Given this list of marker genes SMARCA2, OGT, ARID4B, REST, TET1, DSG2, ACTB, LNCPRESS1, SAP30, ACTL6A, ESRRB, ZNF322, KDM2B, SIN3A (SIN3 transcription regulator family member A), SMARCA4, RBBP7, NCOA3, PRDM14, BRMS1L (BRMS1 like transcriptional repressor), SUDS3, ARID1A, BRMS1, SMARCB1, BRD9, RBBP4, LBH, SS18, SMARCE1, SAP130, BICRAL, ARID4A, ING1, HDAC1, YAP1, BICRA, HDAC2, DPF2, TP63, SMARCD1 (SWI/SNF related, matrix associated, actin dependent regulator of chromatin, subfamily d, member 1), ACTL6B, SMARCC1, SIRT6, SAP30L, BCL7B, TEAD4, SINHCAF (SIN3-HDAC complex associated factor), BCL7A, PHF10, BCL7C, ING2, here is a description of the gene set: Human Gene Set: GOBP_POSITIVE_REGULATION_OF_STEM_CELL_POPULATION_MAINTENANCE Any process that activates or increases the frequency, rate or extent of stem cell population maintenance. species: Homo sapiens